The following is a description of a gene set: Up-regulated in GHOST(3)CXCR4 cells (osteosarcoma) upon ectopic expression of ILF3. Human Gene Set: KRASNOSELSKAYA_ILF3_TARGETS_UP Viral infection triggers a cascade of interferon response genes, but the mechanisms that prime such innate antiviral defenses are poorly understood. Among candidate cellular mediators of the antiviral response are the double-stranded RNA (dsRNA)-binding proteins. Here we show that a C-terminal variant of the ubiquitous dsRNA-binding protein, nuclear factor 90 (NF90ctv), can activate the interferon response genes in the absence of viral infection. NF90ctv-expressing cells were infected with the syncytium-inducing HIV-1 strain NL4-3 and were shown to inhibit viral replication. To gain insight into this mechanism of protection, we analyzed the expression profiles of NF90ctv-positive cells as compared with parental cells transduced with the empty vector. Of the genes represented on the expression arrays, 90 displayed significant (4-fold or more) changes in mRNA levels in NF90-expressing cells. About 50% are known interferon alpha/beta-stimulated genes. The microarray expression data were confirmed by quantitative reverse transcriptase-polymerase chain reaction analysis of six representative interferon-inducible genes. Electrophoretic mobility shift assays showed that the biological response is mediated by the activation of transcription factors in NF90ctv-expressing cells. Functional significance of the activated transcription complex was evaluated by transfection assays with luciferase reporter constructs driven by the interferon-inducible promoter from the 2'-5'-oligoadenylate synthetase (p69) gene. Resistance to HIV-1, caused by the expression of NF90ctv in the cell culture system, appears to be mediated in part by the induction of interferon response genes. This leads to a hypothesis as to the mechanism of action of NF90 in mediating endogenous antiviral responses. from publication Krasnoselskaya-Riz I, Spruill A, Chen YW, Schuster D, Teslovich T, Baker C, Kumar A, Stephan DA (PMID 12036489) studied in species Homo sapiens, and this is the list of marker genes: NT5E, IFITM1, RGS4, TBX5, OAS1 (2'-5'-oligoadenylate synthetase 1), HBE1, HLA-E (major histocompatibility complex, class I, E), CLEC2B, IFI16 (NCBI Gene Id 3428), MX1, BLZF1, H1-2, EMP1, CFH, APOE, IL6ST, IFI27, TSPAN8, TUBBP1, PLAU, TAP1, PROS1, IFI6, PSMB9, PLSCR1, OMD, XAF1, CTSO, STAT1 (signal transducer and activator of transcription 1, NCBI Gene Id 6772), BDKRB2 (NCBI Gene Id 624), H2AC6, ISG15, IFIT1 (NCBI Gene Id 8374), CST4, IFI35, MX2, TRIM22, IFIT3, FAP, HBG1